The following is a description of a gene set: Human Gene Set: GSE24671_CTRL_VS_SENDAI_VIRUS_INFECTED_MOUSE_SPLENOCYTES_UP The genome of vertebrates contains endogenous retroviruses (ERVs) that have resulted from ancestral infections by exogenous retroviruses. ERVs are germline encoded, transmitted in a Mendelian fashion and account for about 8% of the human and 9.9% of the murine genome, respectively1, 2. By spontaneous activation and reintegration ERVs may cause insertional mutagenesis and thus participate in the process of malignant transformation or progression of tumor growth3, 4. However, if the innate immune system is able to recognize and control ERVs has not yet been elucidated. Here we report that, in vitro, nucleic-acid sensing TLRs on dendritic cells are activated by retroviral RNA and DNA from infected cells in vitro. Infection of TLR competent wild type mice with murine leukemia virus (MuLV)-like ERV isolates results in non-canonical gene upregulation, independent of type I IFN. In vivo, TLR3, -7 and -9 triple deficient mice (TLR379-/-) and mice with non functional TLR3, 7 and 9 signaling due to a mutation in UNC93B develop spontaneous ERV-induced viremia. More importantly, in TLR379-/- mice ERV-induced viremia correlates with acute T cell lymphoblastic leukemia (T-ALL). Multiple independent TLR379-/- T cell leukemia lines produce infectious MuLV of endogenous origin. These cell lines display de novo retroviral integration into the Nup214 or Notch1 gene locus leading to gene dysregulation that is reminiscent of aberrant Nup214 and Notch1 expression in human T-ALLs5. Overall, our results demonstrate that in addition to their role in innate immune defense against exogenous pathogens, TLR3,-7, and -9 may be essential for the control of endogenous retroviral mediated T-cell lymphomagenesis. species: Homo sapiens from publication Yu P, Lübben W, Slomka H, Gebler J, Konert M, Cai C, Neubrandt L, Prazeres da Costa O, Paul S, Dehnert S, Döhne K, Thanisch M, Storsberg S, Wiegand L, Kaufmann A, Nain M, Quintanilla-Martinez L, Bettio S, Schnierle B, Kolesnikova L, Becker S, Schnare M, Bauer S (PMID 23142781) Genes up-regulated in splenocytes: control versus infected with Sendai virus., and this is the list of marker genes: AFF3, F2R, MT-CYB, MYG1, GPR18, VPS41, FAM184B, PHETA2 (NCBI Gene Id 150368), MCTP2, NCOA7, AGPAT4, TNS3, CD4, ACP3, IL18R1 (NCBI Gene Id 8809), TEC, NCR1, PTPRA, APPL2, LTA, ARID4A, DDX6, STOM, SHISA5 (shisa family member 5), MYO1F, KCNK1, DOCK10, RGS12, ABI3BP, MIDN, BATF3, PTPRJ, GSTA3, JAML, HHEX, CLCN3, NKAPD1 (NKAP domain containing 1), GPR108, MTX2, BLTP3B, MGAT4A, MGA, S1PR3, TMEM176B, RABGAP1, RCBTB1, SLC6A12, IPCEF1, NEBL, PRAM1, PGLYRP1, CXCR5, HPS4, IGF1R, PARP14, TUBGCP6, TTN (NCBI Gene Id 7847), B4GALT6, FCER1G, CCDC88A, DENND3, ACSL1, RTN4RL1, SAFB, GCNT2, CLDND1, CASP4, ARHGEF28, EEF2K, IL17RE, IL7R, TMEM176A, ANKRD33B, PLCB4 (phospholipase C beta 4), MAPK10, PIGA, ATP8B4, CCR6, MACF1, SLC28A2, RIT1, SCN3B, IL1R1, RIPOR2, PDE4B, RAB21, XKRX, ADGRG5, OGT, DNAJC10, RASA3, UBR2, TMEM154, SLC16A7, COLGALT2, TDRD9, IDI2, NRG2, ATF7IP, RNF43, LINGO4, ZFAND6, GPR15, UPP1, ASB2, AOAH, IL23R, SMYD2, LRRK2, PODNL1, GDPD5, PTMS, DOCK8, SUSD2 (NCBI Gene Id 56241), SENP3, RNASEL, PLCG2, CDC14A, DHRS3, TNC, ITGA4, PSMB9, TXK, AIF1, KCNIP3, ITGA5, DSCAM, CHD2, OAZ3, SLC6A13, GRIA3 (glutamate ionotropic receptor AMPA type subunit 3), CD7, SERINC2, DENND4C, CNTN1, CLNK, MALAT1, STOML2, DLL1, ZC3H13, HNRNPH3, ARHGAP6, TXNRD1, NUSAP1, EPSTI1, HMGN3, CD74, GPR146, REST, PSD2, LARGE1, CELF2, SNAP23, RAB27A, RORC, EP300, ANGPTL1, PHIP, TM9SF2, CTSS, ARHGDIB